Given this list of marker genes NDUFAB1, LYRM4, NFS1, ISCU, FXN, here is a description of the gene set: Human Gene Set: GOCC_MITOCHONDRIAL_2FE_2S_ASSEMBLY_COMPLEX A protein complex capable of forming 2Fe-2S clusters in mitochondria. In humans it consists of ISCU, NFS1, LYRM4, NDUFAB1 and FXN. studied in species Homo sapiens